Given this list of marker genes MGAT2, here is a description of the gene set: Alpha-1,6-mannosyl-glycoprotein 2-beta-N-acetylglucosaminyltransferase (MGAT2) normally catalyses the transfer of a GlcNAc moiety onto the alpha-1,6 mannose of an alpha-1,4 branch of oligomannose N-glycans to form complex N-glycans. Defects in MGAT2 are associated with congenital disorder of glycosylation type IIa (MGAT2-CDG, CDG-2a; MIM:212066), a multisystem disorder caused by a defect in glycoprotein biosynthesis and characterised by under-glycosylated serum glycoproteins. Type II CDGs refer to defects in the trimming and processing of protein-bound glycans. species: Homo sapiens Reactome Pathway: Defective MGAT2 causes CDG-2a part of: Diseases associated with N-glycosylation of proteins